The following is a description of a gene set: studied in species Homo sapiens from publication Amit I, Garber M, Chevrier N, Leite AP, Donner Y, Eisenhaure T, Guttman M, Grenier JK, Li W, Zuk O, Schubert LA, Birditt B, Shay T, Goren A, Zhang X, Smith Z, Deering R, McDonald RC, Cabili M, Bernstein BE, Rinn JL, Meissner A, Root DE, Hacohen N, Regev A (PMID 19729616) mouse primary BMDCs were stimulated with tlr ligands and gene expression changes were profiled on Affymetrix arrays Genes down-regulated in comparison of dendritic cells (DC) stimulated with poly(I:C) (TLR3 agonist) at 6 h versus DC cells stimulated with CpG DNA (TLR9 agonist) at 6 h. Human Gene Set: GSE17721_POLYIC_VS_CPG_6H_BMDC_DN, and this is the list of marker genes: PGS1, GABARAPL2, ABCG2, RALB, ANAPC7 (anaphase promoting complex subunit 7), EEF2K, FAH, STX4, ERLEC1, SLC4A2, CCDC92, SDHC, TLL2, RNF141, MFSD14B, CKS2, NFKB2, TARBP2, ARHGAP1, CLMP, GADD45B, RILPL2, POU4F3, THBS1 (NCBI Gene Id 7057), SF3B3, MRPL23, MAT2A, C5orf47, VCAN, PER3, HYPK, COPS5, RIOK2, MOAP1, TMBIM1, TMED7, SPP2, DDX54, AATF (NCBI Gene Id 26574), CLEC4D, LIMD1, GATAD1, SEC61G, PPTC7 (protein phosphatase targeting COQ7), HMGCS1, ARFRP1, DEXI, PCBP4, TRAPPC5, GAS7, PRKRIP1, KLF5, TRAF3IP2, EMC7, NOS1, CCL13, MAPRE2, ACAD9, PRKD1, TLR6, HGS, RHBDL3, TMEM158, C11orf58, ZNHIT1, WDR43, PTPN11, RABIF, LCP1, TMX1, PSMC5, CATSPERZ, HERC2, PGRMC2, ETS2, FGF2, SMAP1, USP9X, GFRA2, MYL11, CMTR1, RHOB, KRT2, MAGOHB, RWDD1, HS1BP3, RCC1L, GPD2, PTGES2, ABHD17C, RAB34, ELP5, ATP13A3 (NCBI Gene Id 79572), ADAM17, CKAP5, PURB, GPC1, NRF1, IPO4, NNT, STK17B, SLFN12L, CYP3A4, SLAIN2, RRAS2, SAR1A, DIO1, MSANTD4, DHRS1, ZNF106, TFPI, ADRA2A, ERO1A, AMMECR1L, PABPC4, SRGN, RPL22L1, LGR6, PPIF, PSMD7, CRTC2, SRCIN1, MARCKSL1, THOC1, NMD3, STRN4, CD302, EIF5, RBM38, UTP4, UTP18, NUP160, TOP1, PPP1CB, LYAR, CCN3, SEPTIN11, SLC35A4, ZNF296, PHLDA1, CHST11, RRP1, XYLT2, HJURP (Holliday junction recognition protein), ELOVL1, PICALM, RAP2A, ALDH1A1, SMIM30, TMED5, TMEM120B, NME6, IFT22, GPR37L1, PLPPR2, ARHGEF12, COX19, TMA7, RNPC3, PTGER4, MYLIP, F10, TP53RK, TEAD4 (NCBI Gene Id 7004), HMGA2, FGFR3, GRK2, CYFIP2, MLF2, OLR1, MFSD14A, NLRP3, CSTB, HSPA5, UBL5, PPIC, GFER (growth factor, augmenter of liver regeneration), MYL6, TBX19, EIF4E, DNAJB6, EREG, VCP, ABCC1, GFI1B, SUCO, INSM1, MRPS7, SELE, AOAH, CAP1, RRP36, PSMB2, BRAF, MYH1, SPRTN, FOXD2, SQLE (NCBI Gene Id 6713), BTG2, CAPN2